Given this list of marker genes Samd3, Sptlc2, Nsun4, Rnf13, Mkln1, Api5, Serpinb3c, Smarca5, Klf8, Ngly1, Fam199x, Cryz (crystallin, zeta), Ptchd1, Vmn1r32, Slc2a13, Pnpt1, Wdr76, Lpp, Usp1, Semp2l2a, Ephb1, Hecw2, Prr32, Fgf13, Dio2, Spcs1, Cdk12, Rbms3, Ino80d, Wfdc17, Jazf1, Lrat, Recql, Zfp677, Sytl5, Vmn2r89, Gng2, Dbndd2, Hcn1, Armc1, Vmn2r37, Zscan18, Slc40a1, Arf4, Dmd, Mier3, Kcnb2 (potassium voltage gated channel, Shab-related subfamily, member 2), Zfp735, Plscr4, Usp25 (ubiquitin specific peptidase 25), Commd6, Hhip, Actr6, Rgs13 (regulator of G-protein signaling 13), Paip1, Itsn1, Mitf, Med18, Jarid2 (jumonji and AT-rich interaction domain containing 2), Tsr1, Ppp3r1, Phldb2, Dusp15, Gpr22 (NCBI Gene Id 73010), Itih5, Paip2, Klrc1, Mbnl1, Tmem47, Stpg2, Serpinb3b, Lcorl, Zfp36l1, Dnase2b, Nectin3, Tmem69, Btbd10, B230219D22Rik, Aqp5, Kpna3, Wapl, Car3, Nbea, Xk, Tlr3, Zdhhc6, Slc25a53, Ids (NCBI Gene Id 15931), Stx7, Nrxn1 (neurexin I), Lypd8, Klhl26, Car13, Samd4, Sptssb, Naip6 (NCBI Gene Id 272660), Tmem200a, Plcxd2, Slit2, Epha7, Zup1, Rnf19a, Cdh8, Itgav, Wsb1, Nsd3, Lrrc58, Il22ra2, Atp2b1, Colgalt2, Ephb3, Hfm1, Armcx4, Chrna5, Ankrd17, Ercc6, Krt31, Plekhg1, Psrc1, St18, Glrx2, Rere, Osbpl8, Slc1a2, Fhip1b, Esp34, Vipr2, Ifi205, Fam227b, Tmem50b, Rnf4, Reps2 (RALBP1 associated Eps domain containing protein 2), Eya1, Arhgap42, Slc25a35, Zfp830, Samd13, Nrep, Rab1a, Zfp748, Perp, Col19a1, Ifi211, Mtmr1, Clec4f, Gmfb, Angpt1, Yipf4, Prdm1, Itm2b, F13a1, Tcf24, Nucks1, Iqgap2, Bax, Myef2, Gm12887, Wdr37, Ephb4, Tm9sf2, Gphn, Hdac8, Ostn, Rspo3, Mixl1, Rnf115, Fmo1, Nrk, Txk, Dck, Trpm3, Pphln1, Ube2v1, Ntrk3, here is a description of the gene set: Genes predicted to be targets of miRBase v22 microRNA mmu_miR_7013_5p in miRDB v6.0 with MirTarget v4 prediction scores > 80 (high confidence targets). Mouse Gene Set: MIR_7013_5P from publication Chen Y, Wang X (PMID 31504780) species: Mus musculus